The following is a description of a gene set: The assembly of cristae, the inwards folds of the inner mitochondrial membrane. studied in species Homo sapiens Human Gene Set: GOBP_CRISTAE_FORMATION, and this is the list of marker genes: CHCHD3, LETM1, UQCC3, APOO, MICU1, CHCHD6, DNAJC11, SLC25A46, IMMT, PINK1, MICOS13, OPA1, APOOL, TAFAZZIN, OMA1, SAMM50, AFG3L2, MICOS10, ADCK1, CHCHD10